Given this list of marker genes ZNF367, HMGN2, TOP2A, SKA2, KIF2C, EZH2, H2AZ1, GNLY, CDC25C, CLSPN, GINS2, ATAD5, RPA3, APOBEC3B, RANBP1, POLQ, CENPF, CENPN, SNRPB, KLRF1, GGH, HMGN3, RCC1, PPIA, CDK1, CKS2, MCM10, UBE2C, KIF22, SMC4, C12orf75, MCM7, HELLS, TK1, CCNA2, NCAPH, ATAD2, FGFBP2 (NCBI Gene Id 83888), E2F1, DNMT1, KIF14, RRM2, CCDC167, DCTN3, BRCA2, ASF1B, DIAPH3, MCM6, HPRT1, STMN1, TROAP, PKMYT1, PXMP2, RFC4, UBE2T, DTL, HMGB1, LSM5, SMC2, TACC3, TYMS, DYNC2I2, TPX2, SH2D1B, RAD51AP1, CDCA3, APMAP, AKR1C3, PSMD8, PSMC3, BIRC5, CDT1, IDH2, PTMA, SKA3, C21orf58, ORC6, DUSP2, AURKB, HMGB2, OIP5, MND1, FANCD2, MCM4, NUCB2, SNRNP25, MELK, H2AZ2, FANCI, GZMB, DUT, SLBP, MAD2L1, CDC45, CENPM, GTSE1, CENPK, GMNN, CDKN3, NDC80, NUF2, HMMR, ASPM, CDC20, PCNA, MCM5, MYBL2, DHFR, TUBB4B, S1PR5, DNAJC9, RAN, ZWINT, MCM3, CENPH, TUBA1B, IGFBP7, CENPU, TUBG1, CDCA8, PRSS23, ICAM2, EBP, TMEM106C, NUDT1, MKI67, CD160, CKS1B, FEN1, here is a description of the gene set: Human Gene Set: TRAVAGLINI_LUNG_PROLIFERATING_NK_T_CELL species: Homo sapiens from publication Travaglini KJ, Nabhan AN, Penland L, Sinha R, Gillich A, Sit RV, Chang S, Conley SD, Mori Y, Seita J, Berry GJ, Shrager JB, Metzger RJ, Kuo CS, Neff N, Weissman IL, Quake SR, Krasnow MA (PMID 33208946)